Given this list of marker genes CD1D, CCN2, BCL6, CSF1R, CCL4, STAT4, HLA-DQA1, TNFAIP6, TLR8, RIN2, TLR7, ANPEP, TMT1A, GPAT3, ASGR1, AP1S2, CYP1B1, HLA-F, IL4I1, FUT7, PRKCD, CD86, SAMSN1, HS3ST3B1, RGL1, here is a description of the gene set: Many vaccines induce protective immunity via antibodies. Systems biology approaches have been used to determine signatures that can be used to predict vaccine-induced immunity in humans, but whether there is a 'universal signature' that can be used to predict antibody responses to any vaccine is unknown. Here we did systems analyses of immune responses to the polysaccharide and conjugate vaccines against meningococcus in healthy adults, in the broader context of published studies of vaccines against yellow fever virus and influenza virus. To achieve this, we did a large-scale network integration of publicly available human blood transcriptomes and systems-scale databases in specific biological contexts and deduced a set of transcription modules in blood. Those modules revealed distinct transcriptional signatures of antibody responses to different classes of vaccines, which provided key insights into primary viral, protein recall and anti-polysaccharide responses. Our results elucidate the early transcriptional programs that orchestrate vaccine immunity in humans and demonstrate the power of integrative network modeling. Genes negatively correlated with antibody response in peripheral blood mononuclear cell in adults (18-45) after exposure to Menomune A/C/Y/W-135, time point 3D species: Homo sapiens from publication Li S, Rouphael N, Duraisingham S, Romero-Steiner S, Presnell S, Davis C, Schmidt DS, Johnson SE, Milton A, Rajam G, Kasturi S, Carlone GM, Quinn C, Chaussabel D, Palucka AK, Mulligan MJ, Ahmed R, Stephens DS, Nakaya HI, Pulendran B (PMID 24336226) Human Gene Set: LI_PBMC_MENOMUNE_A_C_Y_W_135_AGE_18_45YO_CORRELATED_WITH_ANTIBODY_RESPONSE_3DY_NEGATIVE